The following is a description of a gene set: Selected genes up-regulated in DU145 and PC-3 cells (prostate cancer) after treatment with the NSAID (non-steroid anti-inflammatory drug) sulindac. from publication Zerbini LF, Czibere A, Wang Y, Correa RG, Otu H, Joseph M, Takayasu Y, Silver M, Gu X, Ruchusatsawat K, Li L, Sarkar D, Zhou JR, Fisher PB, Libermann TA (PMID 17178890) Numerous studies show that nonsteroidal anti-inflammatory drugs (NSAIDs) are effective in chemoprevention or treatment of cancer. Nevertheless, the mechanisms underlying these antineoplastic effects remain poorly understood. Here, we report that induction of the cancer-specific proapoptotic cytokine melanoma differentiation associated gene-7/interleukin-24 (MDA-7/IL-24) by several NSAIDs is an essential step for induction of apoptosis and G(2)-M growth arrest in cancer cells in vitro and inhibition of tumor growth in vivo. We also show that MDA-7/IL-24-dependent up-regulation of growth arrest and DNA damage inducible 45 alpha (GADD45alpha) and GADD45gamma gene expression is sufficient for cancer cell apoptosis via c-Jun NH(2)-terminal kinase (JNK) activation and growth arrest induction through inhibition of Cdc2-cyclin B checkpoint kinase. Knockdown of GADD45alpha and GADD45gamma transcription by small interfering RNA abrogates apoptosis and growth arrest induction by the NSAID treatment, blocks JNK activation, and restores Cdc2-cyclin B kinase activity. Our results establish MDA-7/IL-24 and GADD45alpha and GADD45gamma as critical mediators of apoptosis and growth arrest in response to NSAIDs in cancer cells. species: Homo sapiens Human Gene Set: ZERBINI_RESPONSE_TO_SULINDAC_UP, and this is the list of marker genes: FOXO3, CEBPB, CXCL8, IL6, PAK2, CEBPG, IL24 (NCBI Gene Id 11009), ATF3, GADD45A